Given this list of marker genes SYNGR3, SYT11, SCN2A, CHRNB1, SNCAIP, SYT5, KCND1, ANK2, ASIC1, KCNB1, GABBR1, KCNAB1, STX3, MAP1LC3A, CA10, KCNK2, SCG5, CNR1, here is a description of the gene set: MicroRNAs (miRNAs) are a class of small noncoding RNAs that regulate gene expression at the posttranscriptional level. Research on miRNAs has highlighted their importance in neural development, but the specific functions of neurally enriched miRNAs remain poorly understood. We report here the expression profile of miRNAs during neuronal differentiation in the human neuroblastoma cell line SH-SY5Y. Six miRNAs were significantly upregulated during differentiation induced by all-trans-retinoic acid and brain-derived neurotrophic factor. We demonstrated that the ectopic expression of either miR-124a or miR-125b increases the percentage of differentiated SH-SY5Y cells with neurite outgrowth. Subsequently, we focused our functional analysis on miR-125b and demonstrated the important role of this miRNA in both the spontaneous and induced differentiations of SH-SH5Y cells. miR-125b is also upregulated during the differentiation of human neural progenitor ReNcell VM cells, and miR-125b ectopic expression significantly promotes the neurite outgrowth of these cells. To identify the targets of miR-125b regulation, we profiled the global changes in gene expression following miR-125b ectopic expression in SH-SY5Y cells. miR-125b represses genes that contain the seed match sequence of the miRNA and/or that are predicted to be direct targets of miR-125b by conventional methods. Pathway analysis suggests that a subset of miR-125b-repressed targets antagonizes neuronal genes in several neurogenic pathways, thereby mediating the positive effect of miR-125b on neuronal differentiation. We have further validated the binding of miR-125b to the miRNA response elements of 10 selected mRNA targets. Together, we report here for the first time the important role of miR-125b in human neuronal differentiation. Human Gene Set: LE_NEURONAL_DIFFERENTIATION_UP species: Homo sapiens Genes up-regulated during neuronal differentiation of SH-SY5Y cells (neuroblastoma) in response to stimulation by tretinoin (all-trans retinoic acid, ATRA) and BDNF. from publication Le MT, Xie H, Zhou B, Chia PH, Rizk P, Um M, Udolph G, Yang H, Lim B, Lodish HF (PMID 19635812)